Given this list of marker genes Tspo, Hspa5, Sppl2c, Arl2, Sufu, Morc3, Kdelr1, Hdac3, Insig1, Hk1, Sp100, Supt7l, Cdk5, Grk2, Kdelr3, Os9, Txn1, Pml, Rangap1, Taf8, Skp1, Ciz1, Sun1, Fkrp, Fam76b, Akt1, Tmed2, Park7, Topors, Insig2, Syne1, Gja1, Sun2, Frey1, Taf3, Rer1, Hk2, Grik5, Pgr, Hnrnpu, Arl2bp, Ankrd13c, Bard1, Bbs4, Pink1, Nr5a1, Kdelr2, here is a description of the gene set: Any process in which a protein is maintained in a specific location a specific location on or in an organelle, and is prevented from moving elsewhere. Encompasses establishment of localization in the membrane or lumen of a membrane-bounded organelle. Mouse Gene Set: GOBP_MAINTENANCE_OF_PROTEIN_LOCALIZATION_IN_ORGANELLE studied in species Mus musculus